Given this list of marker genes GCSH, BOLA3, ISCU, AMT, GLDC, LIPT2, GLRX5, SHMT1, DLD, NFU1, IBA57, LIAS (NCBI Gene Id 94182), LIPT1, HSCB, PNPO, here is a description of the gene set: Human Gene Set: WP_GLYCINE_METABOLISM_INCLUDING_IMDS species: Homo sapiens Glycine metabolism, including IMDs